Given this list of marker genes AKIRIN1, SUV39H2, TMEM147, SYT11, GNB4, TIPRL, ZNF367, CTC1, TEX14, STAG1, TAOK2, CDX4, MLF2, EBF1 (EBF transcription factor 1), RAI1, SLC38A1, KCTD8, ASPHD1, LDHA, CCN4, CHMP1B, SIK1, HOXC10, MRRF, PLCD3, PAFAH1B1, DDX51, SNAP25, PTPRU, WFDC3, YTHDC2, ZNF184, IKBKB, NDUFA10, NDUFB2, CBX8, IRF2BPL, CCDC148, JUND, KYAT1, DNTTIP1, MAP3K13, PARD6A, CYSTM1, HAS1, NUP98 (NCBI Gene Id 51457), CENPE, RNF44, SLC25A25, RAB25, LGR5, MAOA, GEM, TMEM59L, ZNF576, ALS2, ADAP1 (ArfGAP with dual PH domains 1), SENP2, XPNPEP3, STAT3, SCAMP5, KCNF1, NOC4L, BNIP3L, ATP6V0C, UMPS, AMER2, GPBP1, OSR1, ADNP2, ID1, ZC3H10, NEUROD6, RUNDC3A, GTF3C1, DAAM2, RCAN1, MADD, DUSP1, ING4, MRGPRF, ZNF516-DT, ARL4D, HS3ST3A1, RUSC1-AS1, EPB41, HOXB9, CLSTN3, CREM, CLDN6, RELB, RUSC1, ATG5, ZIM2, TSPAN7, ELOVL5, KCNA5, PPM1A, WNT10A, CCNA2, AHI1, DDX19A, CYLD, NCAM1, LMCD1, LMBRD1, CAMK2D, INO80, VPS37B, RPS29, EPHA2, CDS1, ETV6, MAPK10, SGIP1, AFF4, GLOD4, HHIP, ZBTB37, MAP1LC3A, C11orf87, BRAF, AREG, SYNCRIP, RIPOR1, ELAVL1, EEF2, NUBPL, TRPC1, FOXD3, YME1L1, CLCN3, PDLIM3, DUS2, SEC24C, ZNF335, ZNF593, ZFAND2B, ZHX2, LENG9, GLI1, H4C5, ZMYND15, RCE1, SPAG9, THADA, PKP4, SDHB, RAD51C, YWHAZ, SEMA4C, SLC7A3, SRRM4, CRH, DENND5A, TMEM39A, PPARGC1A, DIO2, DNAJC27, SULT4A1, PPP1R15A, GPM6B, OSBPL9, DEPDC4, ATL2, RPRD1A, NR2E1, G3BP2, PITX2, AVPI1, GNL1, PRR3, MAFF, ARIH1, PPP2R2A, USP48, SP1, PNRC1, ADCY8 (NCBI Gene Id 114), NCALD, PACRGL, VGF, PER1, CD2AP, MMGT1, ABHD16A, PHC1, IRX4, MCAM, DCTN1, THOC1, ZMYM2 (zinc finger MYM-type containing 2), RBKS, OGDH, ST13, UBE2H, RBP5, FAM174A, TNFAIP1, MRM3, FGF6 (fibroblast growth factor 6), CMSS1 (cms1 ribosomal small subunit homolog), SPATA7, PNMA6A, TGIF2, NUP42, CHPF, DDX28 (DEAD-box helicase 28), MAF, SST, MBNL2, EGR1, B3GALT2, CSTF3, CLDN7, NF1, RALGAPA1P1, IFT20, HDX, CHGB (NCBI Gene Id 1114), PHACTR3, ZFYVE27, UCN, ZBTB11, ANAPC10, SYNGR3, PNMA3, PCSK1, TSC22D2, SCG2, RNF7, PDP1, TRAP1, PFAS, MITF, LTBP1, NR4A2, SLC18A2, CXCL16, TBC1D32, TH, TP53INP2, NUP214, INTS7, HCRTR2, RBM18, PEG3, C1orf35, DHX36, FLT1, BABAM2, TRAF4 (NCBI Gene Id 9618), FAM131A, ELL2, HS3ST2, MYL6, RPL41, NOL4, HSP90AB1, IRX6, GPR3, KICS2, CMTR1, ABCE1, here is a description of the gene set: Genes having at least one occurrence of the motif TGACGTYA in the regions spanning 4 kb centered on their transcription starting sites. This matches the JUN, ATF2 transcription factor binding site V$CREBP1CJUN_01 (v7.4 TRANSFAC). Human Gene Set: CREBP1CJUN_01 species: Homo sapiens